Given this list of marker genes MAFB, B2M, IDUA, COMP, MFN2, FLI1, SEPTIN9 (septin 9), KRT14, KRT5, here is a description of the gene set: An unpleasant sensation characterized by physical discomfort (such as pricking, throbbing, or aching) localized to the arm. Human Gene Set: HP_UPPER_LIMB_PAIN studied in species Homo sapiens Upper limb pain